The following is a description of a gene set: Genes down-regulated in CD4 T cells treated with halofuginone: 3h versus 6h. Human Gene Set: GSE15624_3H_VS_6H_HALOFUGINONE_TREATED_CD4_TCELL_DN studied in species Homo sapiens from publication Sundrud MS, Koralov SB, Feuerer M, Calado DP, Kozhaya AE, Rhule-Smith A, Lefebvre RE, Unutmaz D, Mazitschek R, Waldner H, Whitman M, Keller T, Rao A (PMID 19498172) T cell differentiation to the Th17 effector subset requires stimulation through the T cell and co-stimulatory receptors, together with cytokine stimulation by TGFb and IL-6. The small molecule halofuginone (HF) inhibits Th17 cell development and induces a pattern of stress-regulated gene expression that mimics amino acid starvation. We used global transcript profiling to ask how halofuginone modulates gene expression induced during T cell activaiton and Th17 differentiation, and this is the list of marker genes: FAM117B, GPBP1, RNF114 (NCBI Gene Id 55905), ARID1B, TNFRSF10B, ING3, ZYG11B, EXOSC4, FAM8A1 (family with sequence similarity 8 member A1), ZKSCAN1, FOXRED2, CSRNP1, PLXNB3 (plexin B3), GRID1 (NCBI Gene Id 54547), NFYA (NCBI Gene Id 56008), PFKL, BIRC3, IZUMO1R, TMEM33, PPP1R9B, ZBTB14, ART4, MPHOSPH10, PSMD11, MED22, SAR1A, LARP1, HIF1AN, IGF2R, RASGRF1, MIR129-2, RACGAP1, DAGLA, KRTAP24-1, LYZL4, NPY2R, FBXW11, GALNT10, GLIS1, GTF2I, TAPBP, IL2RB, GRWD1, GPN2, WEE2, PDE2A, TTC4, ARHGAP10 (NCBI Gene Id 79658), RAB27A, MYO16, UBE2O, OTOP3, SLC23A2, PERP, RBSN, THAP12, TMEM59, LCP1, TMEM179, CORO2A, FGG, VPS37B, MAP3K4, SEC11A, PINK1, MSRA, GALNS, ANKRD50, PHC1, SKIL, BRAP, CRIM1, USP10, CIBAR1, LRIG3, RBM17, RAD51D (NCBI Gene Id 5892), PRAMEF8, SLC3A2, PLEKHG6, RNF145, PRMT6, CCR7, MIR155, HNRNPC, NPW, IFNE, RGS1, WBP11, CBR1, RAD23B, LIF, UBQLN2, KDM2B, TRIM26, PRELID3B, DBR1, PPP1CB, DGKE, ZDHHC5, TSC22D3, SEC13, APPBP2, NGRN, USP12, GABRA3, SF3A3, STAT3, FGF11, ZFP1, LRIG1, MFF, DHX38, SH2D2A, TGFBRAP1, PDE4D, CGGBP1, FAM32A, PPM1G, PLAG1, HAO1, PSMB6, SESN3, PRDX6, NEU3, PARP3, CLSTN1, SLC49A4, TPO, AEBP2, DUSP15, UNC13A, ABHD15, CLDN23, TFPI2, TRAPPC10, PLEKHB2, TUT1, AHCYL2, PAG1, GBP2, LYG1, NRARP, ACOX1, PRKG1, FURIN, TRIM25